The following is a description of a gene set: part of: Epigenetic regulation of adipogenesis genes by MLL3 and MLL4 complexes Reactome Pathway: MLL4 and MLL3 complexes regulate expression of PPARG target genes in adipogenesis and hepatic steatosis species: Homo sapiens The ligand-activated complex of a master transcription regulator of adipogenesis, nuclear receptor PPARG, and its partner, nuclear receptor RXRA, recruits MLL3 and MLL4 complexes to target gene loci, leading to establishment of activating epigenetic chromatin marks. The existing experimental evidence implies that MLL3-ASCOM and MLL4-ASCOM complexes are recruited to PPARG:RXRA-target loci, as described below.<br><br>PPARG isoform PPARG2-positive adipocyte nuclei isolated from visceral adipose tissue show significantly higher expression level of KMT2C, the catalytic subunit of the MLL3 complex, and PAXIP1, a cofactor of MLL3 and KMT2D (MLL4) complexes, than PPARG2-negative nuclei. Based on mouse studies, PAXIP1 (PTIP), an accessory subunit of MLL3 and MLL4 complexes, is required for adipogenesis in mouse embryonic fibroblasts (MEFs) and primary preadipocytes. PAXIP1-deficient MEFs show significant defects in both PPARG- and CEBPA-stimulated adipogenesis. Knockout of Paxip1 gene in brown adipose tissue (BAT) leads to significant decrease of BAT in knockout mice, and a significant decrease of expression of markers shared between white adipose tissue and BAT, such as Pparg, Cebpa, and Fabp4, as well as BAT-specific/prevalent markers Prdm16, Cidea, Mpzl2 (Eva1), Ntrk3, Ucp1, Ppargc1a (Pgc1a), Cox5b and Cox8b. Paxip1 BAT knockout mice are cold intolerant, with impaired cold-mediated induction of genes involved in fatty acid catabolism, such as Cpt1a, Lpl, and Mlycd (Mcd).<br><br>In prostate cancer, KMT2D and PPARG are overexpressed at the protein level relative to the normal tissue. KMT2D knockdown significantly reduces the lipid droplet content in prostate cancer cell lines. In prostate cancer tumors, KMT2D mRNA expression significantly correlates with mRNA expression of lipid metabolism genes FASN, ACC, SCD, and ACLY. KMT2D knockdown in prostate cancer cell lines leads to significant decrease in the mRNA levels of ACC, ACLY, and FASN. Stimulation of PPARG by the synthetic agonist rosiglitazone stimulates lipid synthesis in prostate cancer cell lines, but the effect of rosiglitazone is diminished upon KMT2D knockdown.<br><br>In addition to regulating genes involved in lipid metabolism, the PPARG:RXRA complex and MLL3/MLL4 complexes (Jang et al. 2019: supplementary information) may also regulate expression of some of the genes involved in glucose metabolism and the tricarboxylic acid (TCA) cycle.<br><br>Hepatic steatosis represents the synthesis and accumulation of triglycerides in hepatocytes which can, if prolonged, lead to the development of non-alcoholic fatty liver disease (NAFLD) that can progress to non-alcoholic steatohepatitis (NASH), ultimately resulting in liver cirrhosis. Like Kmt2c (Mll3) delta/delta mice, which express catalytically inactive Kmt2c (Lee, Saha et al. 2008; Lee S., Lee J. et al. 2008), Kmt2d (Mll4)+/- mice, with deletion of one allele of Kmt2d, are resistant to high fat diet-induced hepatic steatosis, with Kmt2d+/- livers accumulating much less fat relative to wild type littermate controls in response to high fat diet feeding. Bulk transcriptomic analysis of Kmt2d+/- mouse livers shows that the expression of a large portion of high fat diet controlled genes requires Kmt2d. Among the defined hepatic steatotic transcription factors, which include MLXIPL (ChREBP), SREBF1 (SREBP1) isoform SREBP1c (SREBP 1C), the liver X receptors (LXRs) – NR1H3 (LXRA) and NR1H2 (LXRB), and PPARG, KMT2D has been reported to associate with LXRs (Lee S., Lee J. et al. 2008) and PPARG (Lee, Saha et al. 2008). No association between mouse orthologs of KMT2D and MLXIPL or SREBP1c could be detected., and this is the list of marker genes: ANGPTL4, RXRA, GPAM, PEX11A, ACSS3, NCOA2, ELOVL5, MED1, EP300, MED4, MED7, H2AC4, RB1, PDK4, ABL1, H2BC26, DPY30, H2AC14, MED27, MED13, SCD5, MGLL, CCNC, H2BC13, NCOR2, ACSL1, NCOA1, H2BC3, H3C1, PAGR1 (PAXIP1 associated glutamate rich protein 1), MED12, MED23, TBL1X, PPARG, CREBBP, H2BC5, DGAT2, PAXIP1, MED24, PPARGC1A, PLIN1 (perilipin 1), CDK8, ADIPOQ, RBBP5, CEBPA, MED16, KDM6A, H2AC7, H2BC11, LPIN1, LPL, MED6, CIDEC, H2BC17, SIRT1, AGPAT2, TBL1XR1, GPS2, KMT2C, MED31, H2BC14, MED14, THRSP (NCBI Gene Id 82916), AJUBA, H2BC12L, H2BC15, H3-3A, H2AZ2, SCD, H2AX, MED30, NCOA3, H2BC9 (H2B clustered histone 9), NCOR1, PLIN4, H2BC12, LIPE, NCOA6, CD36, MED17, HDAC3, ASH2L, NR5A2, KMT2D, PNPLA2, PPARGC1B (PPARG coactivator 1 beta), H4C1, H2BC1 (NCBI Gene Id 255626), H2BC4, H2AJ, H2BC21, PLIN2, H2AC6, WDR5, MED10, H2AC18, H2AB1, FABP4, CDK5, H3C15, MED20, H2AC20, PHLDA1